Given this list of marker genes Nfasc, Vav2, Tuba4a, Sh3gl2, Tuba8, Sptbn2, Egfr, Kif4, Sptbn4, Itga5, Sptan1, Itgav, Tuba1a, Itgb3, Map2k1, Tubb1, Lypla2, Ap2a1, Sptbn1 (NCBI Gene Id 268394), Tubb3, Tubb2a, Tubb4b (NCBI Gene Id 227613), Ap2s1, Csnk2b, Ank1, Sdcbp, Dnm2, Fgfr1, Src, Actb, Sptb, Tubal3, Nrp1, Cltc, Mapk3, Clta, Dnm1, Itgb1, Itga9, Dpysl2, Tubb2b, Tuba3a, Gap43, Sptbn5, Actg1, Dnm3, Rac1, Ap2b1, Numb, Msn, Tuba1c, Tubb4a, Ap2m1, Rdx, Spta1, Ezr, Pak1, Csnk2a1, Ap2a2, Csnk2a2, Tuba3b, Mapk1, Ranbp9, Tuba1b, Map2k2, Tubb6, Itga2b, here is a description of the gene set: species: Mus musculus Mouse Gene Set: REACTOME_L1CAM_INTERACTIONS L1CAM interactions